Given this list of marker genes RNF44, SLITRK4, SCAMP3, ELAVL1, AP1G1, MLEC, C1QL3, PRKCG, CUL5, GAN, UNC45B, KCND2, RUNX2, FBXO11, APP, NFAT5, ZFX, MAP4K3, SEPTIN4, KLF3, UNC5C, MED22, STARD13, THRA, LMX1A, RAN, NTRK3, ABRAXAS2, ZFP91, BACH2, GON4L, ING4, VDAC1, NIPBL, ARID1A, ZHX3, GGT7, BBX, CDK16, ADGRB1, HSPA14, CAMKV, PBX1, YOD1 (YOD1 deubiquitinase), TMCC1, NSD2, ZNRF2, SEPTIN3, TRMT5, here is a description of the gene set: studied in species Homo sapiens Human Gene Set: GGGATGC_MIR3245P Genes having at least one occurence of the motif GGGATGC in their 3' untranslated region. The motif represents putative target (that is, seed match) of human mature miRNA hsa-miR-324-5p (v7.1 miRBase).